Given this list of marker genes BAG3, LMAN1, DNAJA1, MAPT, C11orf65, LRRK2, BAG4, SIAH3, here is a description of the gene set: Any process that stops, prevents or reduces the frequency, rate or extent of establishment of protein localization to mitochondrion. Human Gene Set: GOBP_NEGATIVE_REGULATION_OF_ESTABLISHMENT_OF_PROTEIN_LOCALIZATION_TO_MITOCHONDRION studied in species Homo sapiens